Given this list of marker genes NCAN, FRMD3, WNK3, MAP4K5, SOCS4, DHX33, MAPK1, TENM3, CLVS2 (NCBI Gene Id 387358), VPS13A, FGF14, CLC, TMEM248, PRRC2C, MAGEB2, PICALM, EIF5A2 (NCBI Gene Id 57114), ZNF586, RAPH1, EFNB2, CDK6, LRRC7 (NCBI Gene Id 57554), PRELID3B, TM7SF3 (transmembrane 7 superfamily member 3), GLIPR1, ING3, KPNA1, NRM, TINF2, ASTE1, MEX3A, SPON1, GSPT1, RPS6KA3, SGTB (small glutamine rich tetratricopeptide repeat co-chaperone beta), RNF144A, CLEC6A, VEZF1, FBXO33, MYF5, CAMSAP2, CCDC141, C18orf32, RBM17, SCG3, ZNF708, RHNO1, IFT52, CHD8, CDH8, COPS2, CCDC82, NUDT19, MED14, ADAMTSL3 (NCBI Gene Id 57188), GATAD2A (NCBI Gene Id 54815), FBXO25, GLTP, RAD51B, C8orf34, LSMEM2, JAZF1, SLFN13, LUM, ULK2, SLC46A3, GRM5, PRKG2, CHD6, GABARAPL2, DHX40, SPRED1, CNTN3 (contactin 3), CTDSPL2, APIP, MARF1, NR3C2, PAQR3, SMNDC1, PLXDC2, CEP112, DGKI, TMEM161B, GABRG2, PIGM, NUDT12, SLC7A6, TRHDE, CST11, PM20D2, KIF3A, THAP10, NAP1L1, ZNF326, PCDHGB7 (protocadherin gamma subfamily B, 7), TMPRSS11A, TMED7, FRS2, ZNF781, ANKRD46, ARFIP1, TIGAR, C12orf75, PTGDR, VPS13C, GFPT1, GNPNAT1, RPL17-C18orf32, MIPOL1, ABCB7, DERL1, ENOSF1, UBE2W, CPA3, SAXO2, RUFY2, TEP1, LPP, LRRFIP1, ZNF189, MED13, here is a description of the gene set: Human Gene Set: MIR541_5P species: Homo sapiens from publication Chen Y, Wang X (PMID 31504780) Genes predicted to be targets of miRBase v22 microRNA hsa-miR-541-5p in miRDB v6.0 with MirTarget v4 prediction scores > 80 (high confidence targets).